The following is a description of a gene set: Human Gene Set: GOBP_EPIGENETIC_PROGRAMMING_OF_GENE_EXPRESSION studied in species Homo sapiens A epigenetic process that happens during embryonic development that modulates gene expression potential at later stages of development of the organism, including the adult. Epigenetic regulation takes place via chromatin remodeling either by modifying higher order chromatin fiber structure, nucleosomal histones, or cytosine DNA methylation., and this is the list of marker genes: MTA2, CTCFL, STPG4, GSK3A, ZNF445, SUV39H2, MORC1, ZDBF2, DDB1, PADI6, MYCN, CDKN1C, PIK3CA, MECP2 (NCBI Gene Id 8274), ARID4A, CTCF, ZFP57, TLE6, KDM1B, IGF2, DNMT1 (DNA methyltransferase 1), DNMT3A, ARID4B, DNMT3L, DIRAS3, ASIP, TRIM28, SUV39H1, AXIN1, TET3, PRMT7, NDN, DCAF13, METTL23, EED, DPPA3